The following is a description of a gene set: Human Gene Set: KEGG_MEDICUS_PATHOGEN_HPV_E6_TO_NOTCH_SIGNALING_PATHWAY_N00381 Pathway Definition from KEGG: E6 -| MFNG -| NOTCH -> (NICD+RBPJ+MAML) => (HES1,HEY1) HPV E6 to Notch signaling pathway. Pathway ID: N00381. Pathway type: Pathogen. Pathway class: nt06511 NOTCH signaling. species: Homo sapiens, and this is the list of marker genes: RBPJL, NOTCH3, MFNG, RBPJ, NOTCH2, NOTCH4, MAML1, MAML3, HES1 (hes family bHLH transcription factor 1), HEY1, NOTCH1, MAML2